Given this list of marker genes Rab33b, Hs3st1, Agrp, Sdc1, Sdc4, Abcc5, Gpc1, Il12a, Hspg2, Sdf4, Lrpap1, Il12b, Gpc5, Uxs1, Galnt2, Sdc3, Gpc4, Agrn, Furin (furin, paired basic amino acid cleaving enzyme), Tpst1, Gpc2 (NCBI Gene Id 71951), Sdc2, Vtn, Sod3, Tpst2, Ero1a, Zg16, Gpc3, Gpc6, here is a description of the gene set: The volume enclosed by the membranes of any cisterna or subcompartment of the Golgi apparatus, including the cis- and trans-Golgi networks. species: Mus musculus Mouse Gene Set: GOCC_GOLGI_LUMEN